The following is a description of a gene set: Any process that modulates the frequency, rate, or extent of leukocyte mediated immunity. Mouse Gene Set: GOBP_REGULATION_OF_LEUKOCYTE_MEDIATED_IMMUNITY species: Mus musculus, and this is the list of marker genes: Ptprc, C4bp, Mir181b-2, Spn, H2-T5, Prkcz, Cd46, Tfrc, Tlr2, Clec4g, Tlr9, Paxip1, Trp53bp1, H2-T3, Ripk3, H2-M10.5, Rac2, H2-Q1, Tbx21, Fes, Lamp1, Il2, Foxf1, Mir181b-1, Lgals9, Cd80, Hspd1, Mr1, Hmox1, H2-Ea, Fcer2a, Rasgrp4, Sash3, Stat5a, Stxbp1, Fgr, Cd177, Il4, Rsad2 (NCBI Gene Id 72445), Havcr2, Clec2d, Aplf, Cx3cr1, Ifng (interferon gamma), Adora2b, Il12b, Cd96, Serpinb9b, Mill1, Klrb1c, H2-M2, Sphk2, Pdcd1, Cd24a, Ptpn6, Pnp, Fcgr2b, Slc15a4, H2-M9, Ccr2, Gata1, Pomc, 6030468B19Rik, Hmgb1, Cd40, Ptafr, Trpm4, Il20rb, Stxbp2, H60b (NCBI Gene Id 667281), Ccl2, Nod2, Gata2, Kit, Exosc6, H2-T23, H2-D1, Nppc, Itgam, Rigi, Cxcl1, Ifnb1, Il18r1, Arid5a, Klrb1f, Lypd11, Lag3, Pld2, Map3k7, Stap1, Malt1, Dnase1, Il13ra2, Vsir, Lta, Clec12b, Msh2, Jak3, Serpinb9g, Zbtb1, Nsd2, Igf2, Gfer, Pla2g3, Pvr, F2rl1, Was, Clec7a, Ddx21, Sh2d1a, Azgp1, Il27ra, Nlrp3, Mad2l2, Lep (NCBI Gene Id 16846), Stat6, Kmt5b, Cyrib, Dusp22 (dual specificity phosphatase 22), Tnfsf13, H2-M10.3, Dpp4, Traf6, Spi1, Tgfb1, Ager (advanced glycosylation end product-specific receptor), Il1b, Rasgrp1 (RAS guanyl releasing protein 1), Hspa8, P2rx7, Adora3, Tnfrsf1b, Tlr3, Vamp8, H2-T15, H60c, Abr, Ccl20, Serpinb9f, Cr1l, Exosc3, Parp3, Fadd, Ddx1, Klrc2, Cd274, Foxj1, H2-Q4, Il1r1, Pik3r6, Pdpk1, Itgb2, H2-K1, Atad5, Hfe, Vav1 (NCBI Gene Id 22324), Klrd1, Gimap3, Lilrb4b, Grb2, Il21, C3, Susd4, Cd55b, Mavs, Unc13d, Prkaa1, Calhm6, Nectin4, Klrc3, Tnfsf4, Dhx36, Cr2, Gata3, Tyrobp, Fcer1g, Plcg2, H2-Q7, Lilrb4a, Fbxo38, Serpinb9, H2-M3, Gimap5, Muc4, Cd226 (CD226 antigen), Zp3r, Cd300a, Il13, Gab2, Bst2 (NCBI Gene Id 97478), Xcl1, Ywhag, Ms4a2, Klrb1a, Serpinb9d, Il7r, Klhl22, Ufl1, Serpinb9e, Pagr1a, Serpinb9c, Nectin2 (NCBI Gene Id 19294), Zp3, H2-M11, H2-T13, Btk, Cadm1, Rif1, Bcl6, Pms2, Lyn, Cd81, Klri2, Arg1, Lypd10, Stat5b, H2-Q2, H2-T24, H2-M10.2, Klrc1 (NCBI Gene Id 16641), Il6, Il18, Tlr4, Ndfip1, Crhr1, Ap1g1, Il12a, Fcgr3, Foxp3, H2-M10.4, Cd1d1, Fzd5, Cd28, Il23a, Bcr, Hmces, Shld2, Dnase1l3 (deoxyribonuclease 1-like 3, NCBI Gene Id 13421), Sh2d1b1, Tap1, Cd1d2, H2-M5, Supt6, H2-M10.1, Crtam, Tap2, Arrb2, Klrb1b, Klrk1, Kmt5c, Clnk (NCBI Gene Id 27278), Inpp5d, Il4i1, Cd55, Il18rap, B2m, Fut7, Clcf1, Raet1d, Crk, Smad7, Raet1e, Cd160, Ighg2b, H2-Q6, Ceacam1, Fcer1a, Pram1, BC037156, Ighg1, H2-M1, H2-M10.6, Slamf6, Slc22a13, Trem2, Itgb2l, Klre1, Il4ra, Nckap1l, Stx7, Shld3, Serpinb9h, H2-T22, Ulbp1, Mlh1, Scimp, Snx4, Fcgr1, Tnf, Syk, Ticam1, Hpx, Ahr, Rabgef1, Slamf1, H2-Q10, Nppa, Klri1, Traf2, Ncr3-ps, Shld1, D6Wsu163e, Ppp3cb, Stx4a, Sh2d1b2, Cd84, Dennd1b, 2410137M14Rik, Klrb1, Cxcl5